Given this list of marker genes SYT3, PLA2G4B, CPNE8, PLA2G4E, DYSF, ANXA5, MCTP2, SYT6, SYTL3, SYT8, MCTP1, SYT17, DOC2A, CPNE6, SYT11, SYT12, ANXA2P2 (NCBI Gene Id 304), CPNE3, SYT10, ANXA4, CPNE5, ANXA11, CPNE2, SYT7, RPH3A, ANXA3 (NCBI Gene Id 306), PLA2G4D, CPNE9, CPNE1, ANXA9, ESYT3, ANXA8L1, SYT1, SYT9, SYT15, SYT4, ESYT2, ANXA13, ESYT1, ANXA7, SYT5, SYT2, ANXA8, PCLO, ANXA10, SYT13, CPNE7, C2CD5, PLA2G4A, PLA2G4F, ANXA2, ANXA1, DOC2B, CPNE4, PLA2G4C, ANXA6, here is a description of the gene set: species: Homo sapiens Human Gene Set: GOMF_CALCIUM_DEPENDENT_PHOSPHOLIPID_BINDING Binding to a phospholipid, a class of lipids containing phosphoric acid as a mono- or diester, in the presence of calcium.